The following is a description of a gene set: studied in species Mus musculus The series of events in which a stimulus from a virus is received and converted into a molecular signal. Mouse Gene Set: GOBP_DETECTION_OF_VIRUS, and this is the list of marker genes: Serinc3, Rigi, Zcchc3, Ncr1, Serinc5